The following is a description of a gene set: The directed movement of organelles or molecules along microtubules from the cell body toward the postsynapse in dendrites. Mouse Gene Set: GOBP_ANTEROGRADE_DENDRITIC_TRANSPORT studied in species Mus musculus, and this is the list of marker genes: Kif5b, Kif5c, Stau2, Kif3b, Kif17, Kifap3, Kif3a (NCBI Gene Id 192824), Stau1, Kifc2, Rab17, Flot2, Kif5a